Given this list of marker genes COL4A2, TLL2 (NCBI Gene Id 7093), P3H1, COL20A1, COL4A6, PLOD3, COL26A1, PPIB, COL27A1, P4HA3, COL8A1, COL25A1, COL19A1, COL24A1, COL11A2, PCOLCE, COLGALT1, COL28A1, PLOD1, P3H3, COL6A6, COLGALT2, COL8A2, P3H2, COL17A1, COL4A4, P4HA1, SERPINH1, PCOLCE2, COL16A1, ADAMTS14, COL14A1, COL9A2, COL11A1, COL4A1, COL2A1, COL3A1, COL9A3, COL18A1, COL5A1, COL15A1 (NCBI Gene Id 1306), COL6A1, COL10A1, COL6A2, COL4A5, COL4A3, CRTAP, COL9A1, COL6A3, COL1A1, PLOD2, COL5A3, COL12A1, COL23A1, P4HA2, BMP1, COL1A2, COL7A1, TLL1, COL13A1, COL6A5, COL22A1, COL21A1, P4HB, ADAMTS2, COL5A2, ADAMTS3, here is a description of the gene set: Reactome Pathway: Collagen biosynthesis and modifying enzymes studied in species Homo sapiens The biosynthesis of collagen is a multistep process. Collagen propeptides are cotranslationally translocated into the ER lumen. Propeptides undergo a number of post-translational modifications. Proline and lysine residues may be hydroxylated by prolyl 3-, prolyl 4- and lysyl hydroxylases. 4-hydroxyproline is essential for intramolecular hydrogen bonding and stability of the triple helical collagenous domain. In fibril forming collagens approximately 50% of prolines are 4-hydroxylated; the extent of this and of 3-hydroxyproline and lysine hydroxylation varies between tissues and collagen types. Hydroxylysine molecules can form cross-links between collagen molecules in fibrils, and are sites for glycosyl- and galactosylation. Collagen peptides all have non-collagenous domains; collagens within the subclasses have common chain structures. These non-collagenous domains have regulatory functions; some are biologically active when cleaved from the main peptide chain. Fibrillar collagens all have a large triple helical domain (COL1) bordered by N and C terminal extensions, called the N and C propeptides, which are cleaved prior to formation of the collagen fibril. The C propeptide, also called the NC1 domain, is highly conserved. It directs chain association during intracellular assembly of the procollagen molecule from three collagen propeptide alpha chains. The N-propeptide has a short linker (NC2) connecting the main triple helix to a short minor one (COL2) and a globular N-terminal region NC3. NC3 domains are variable both in size and the domains they contain.<br><br>Collagen propeptides typically undergo a number of post-translational modifications. Proline and lysine residues are hydroxylated by prolyl 3-, prolyl 4- and lysyl hydroxylases. 4-hydroxyproline is essential for intramolecular hydrogen bonding and stability of the triple helical collagenous domain. Prolyl 4-hydroxylase may also have a role in alpha chain association as no association of the C-propeptides of type XII collagen was seen in the presence of prolyl 4-hydroxylase inhibitors. In fibril forming collagens approximately 50% of prolines are 4-hydroxylated; the extent of this is species dependent, lower hydroxylation correlating with lower ambient temperature and thermal stability. Similarly the extent of 3-hydroxyproline and lysine hydroxylation varies between tissues and collagen types. Hydroxylysine molecules can form cross-links between collagen molecules in fibrils, and are sites for glycosyl- and galactosylation.<br><br>Collagen molecules fold and assemble through a series of distinct intermediates. Individual collagen polypeptide chains are translocated co-translationally across the membrane of the endoplasmic reticulum (ER). Intra-chain disulfide bonds are formed within the N-propeptide, and hydroxylation of proline and lysine residues occurs within the triple helical domain. When the peptide chain is fully translocated into the ER lumen the C-propeptide folds, the conformation being stabilized by intra-chain disulfide bonds. Pro alpha-chains associate via the C-propeptides, or NC2 domains for FACIT family collagens to form an initial trimer which can be stabilized by the formation of inter-chain disulfide bonds, though these are not a prerequisite for further folding. The triple helix then nucleates and folds in a C- to N- direction. The association of the individual chains and subsequent triple helix formation are distinct steps. The N-propeptides associate and in some cases form inter-chain disulfide bonds. Procollagen is released via carriers into the exracellular space (Canty & Kadler 2005). Fibrillar procollagens undergo removal of the C- and N-propeptides by procollagen C and N proteinases respectively, both Zn2+ dependent metalloproteinases. Propeptide processing is a required step for normal collagen I and III fibril formation, but collagens can retain some or all of their non-collagenous propeptides. Retained collagen type V and XI N-propeptides contribute to the control of fibril growth by sterically limiting lateral molecule addition. Processed fibrillar procollagen is termed tropocollagen, which is considered to be the unit of higher order fibrils and fibres. Tropocollagens of the fibril forming collagens I, II, III, V and XI sponteneously aggregate in vitro in a manner that has been compared with crystallization, commencing with a nucleation event followed by subsequent organized aggregation. Fibril formation is stabilized by lysyl oxidase catalyzed crosslinks between adjacent molecules (Siegel & Fu 1976). part of: Collagen formation